The following is a description of a gene set: species: Homo sapiens Punding is a stereotypical motor behavior characterized by an intense fascination with repetitive, excessive and non-goal oriented handling, and examining of objects. Punding Human Gene Set: HP_PUNDING, and this is the list of marker genes: GABRA1, GABRB3, JRK, SLC2A1, GABRG2, CACNA1H